The following is a description of a gene set: Reactome Pathway: Phase I - Functionalization of compounds Phase 1 of metabolism is concerned with <i><b>functionalization</b></i>, that is the introduction or exposure of functional groups on the chemical structure of a compound. This provides a 'handle' for phase 2 conjugating species with which to react with. Many xenobiotics are lipophilic and almost chemically inert (e.g. PAHs) so would not necessarily undergo a phase 2 reaction. Making them more chemically reactive would facilitate their excretion but also increases their chance of reacting with cellular macromolecules (e.g. proteins, DNA). There is a fine balance between producing a more reactive metabolite and conjugation reactions.<br>There are two groups of enzymes in phase 1 - oxidoreductases and hydrolases. Oxidoreductases introduce an oxygen atom into or remove electrons from their substrates. The major oxidoreductase enzyme system is called the P450 monooxygenases. Other systems include flavin-containing monooxygenases (FMO), cyclooxygenases (COX) and monoamine oxidases (MAO). Hydrolases hydrolyse esters, amides, epoxides and glucuronides. studied in species Homo sapiens part of: Biological oxidations, and this is the list of marker genes: PTGES3, CYP7A1, AHRR, BPHL, POMC, AOC3 (NCBI Gene Id 8639), CYP1A2, CYP3A5, SMOX, CYP2C18, CES1, CYP1A1, CYP3A4, NR1H4, ADH1B, CYP4A22, CYP4F22, CYP2R1, AOC2, CYP2A6, CYP21A2, CYB5B, CYP8B1, AADAC, CYP3A43, CYP2S1, AIP, HSP90AB1, CYP2J2, EPHX1, ADH6, PTGIS, CYP4F11, CYP26C1, RXRA, ADH1C, ALDH1A1, ADH1A, FDX1, CYP39A1, CYP11B2, NQO2, FMO2, MTARC1, CYP4V2, AHR, CYP4B1, CYP2E1, CYP26A1, PAOX, CYP2C8, CYP4F3, CYP2A7, AOC1, ADH4, CYP2B6, NCOA2, FMO1, CYP51A1, CYP2W1, CES3, ALDH2, ALDH3A1, CYP2C19, CMBL, ACSS1, CYP2U1, CYP2A13, CYB5R3, CYP3A7, CYP1B1, TBXAS1, ALDH1B1, CYP7B1, CYP46A1, CYP11B1, CYP27B1, ARNT, MAOB, CBR3, ACSS2, NCOA1, CYP26B1, CYP4F12, CYP27A1, CYP24A1, MTARC2, FDX2, CYP4A11, CYP2D6, CYP11A1, ADH7, CYP2F1, FDXR, MAOA, CYP4F2, CES2, CYP4F8, POR, FMO3, ARNT2, ADH5, CYP19A1, PTGS1, CYP2C9